Given this list of marker genes Septin14 (NCBI Gene Id 74222), Ywhae, Foxg1, Mef2c, Tnn, Tlx3, Cntn2, Ulk1, Usp9x, Lrp12, Barhl1, Cdkl5, Stat3, Cul5, Fkrp, Srf, Kif20b, Vegfa, Astn1, Gja1 (gap junction protein, alpha 1), Mapk8, Pomgnt2, Auts2, Nipbl, Axl, Psen1, Arhgef2, Katna1, Fbxo45, Ntn1, Chl1 (NCBI Gene Id 12661), Ascl1, Mark2, Ntrk2, Nkx6-1, Ntrk3, Dab2ip, Gata2, Camk2a, Plxnb2, Ndel1, Pafah1b1, Sdccag8, Gsk3b, Esr2, Crk, Matn2, Gpm6a (glycoprotein m6a), Neo1, Cdk5r1, Nexmif, Celsr3, Filip1, Tubb2b, Arx, Met, Arhgap32, Sema6a, Srgap2, Nrp1 (NCBI Gene Id 270112), Vrk1 (vaccinia related kinase 1), Rapgef2, Fbxo41, Acap3, Pex7, Kirrel3, Nrg3, Plaa, Septin4, Celsr2, Dcdc2a, Phox2b (NCBI Gene Id 245706), Top2b, Abi2, Scrt1, Tyro3, Nsmf, Nr4a2, Mark1, Shtn1, Dcc, Camk2b, Crkl, Tuba1a, Drgx, Gnrh1, Olig3, Nkx2-1, Pax6, Pcnt, Pcm1, Gas6, Fezf1, Ndnf, Plxna3, Col3a1, Fezf2, Zmiz1, Bbs4, Elp3, Cdh1, Il1r1, Flna, Nrp2, Twist1, AU040320, Dnaaf4, Sema3a, Satb2, Wasf2, Spock1, Pou4f1, Gfra3, Cckar, Nr2f1, Adgrl3, Gpr173, Ptk2b, Mnx1, Mrtfa, Reln, Large1, Unc5c, Celsr1, Flrt2, Ptk2, Vax1, Fbxo31, Unc5d, Robo3, Fgf13, Pex5, Pex13, Cdk5, Dcx, Mapt, Trim46, Fzd3, Ulk4, Abi1, Rnf7, Wdr62, Cep85l, Dubr, Ccr4, Drd2, Gata3, Bax, Fyn, Sox14, Disc1, Dab1, Pitx2, Ctnna2, Bbs1, Cep85, Tbx20, Aspm, Kif26a, Rhoa, Rac1, Drd1, Apbb2, Nde1, Adam17, Dclk1 (doublecortin-like kinase 1), Mdga2, Lrig2, Mapk8ip3, Sema3e, Igsf10, Scrt2, Unk, Cxcl12, Zfp609, Tubb2a, Ddit4, Lmx1b, Neurog2, Mdk, Zswim6, Mrtfb, Cck, Neurod4, Mdga1, Hsp90aa1, Abi3, D130043K22Rik, Ptprz1, Apbb1, Fat3, Tbc1d24, Nav1, Myh10, Evx1 (NCBI Gene Id 14028), Barhl2, Ndn, Nrg1, Lhx6, Lhx1, Ctnnb1, Nr2f2, Prkg1, Cxcr4, Astn2, Tubgcp2, Emx2, Ntng1, Eomes, Sox1, Itga3, Pex2, Plxna1, Ntng2, Sh3rf1, Fktn, Alkbh1, Phactr1, Adgrg1, Cdk5r2, Atoh1, here is a description of the gene set: Mouse Gene Set: GOBP_NEURON_MIGRATION The characteristic movement of an immature neuron from germinal zones to specific positions where they will reside as they mature. studied in species Mus musculus